The following is a description of a gene set: Mouse Gene Set: REACTOME_DNA_REPLICATION_INITIATION studied in species Mus musculus DNA replication initiation, and this is the list of marker genes: Prim2, Pole4, Pola1, Pole3, Pole2, Prim1, Pola2, Pole